The following is a description of a gene set: Human Gene Set: GOBP_HINDBRAIN_TANGENTIAL_CELL_MIGRATION The migration of a cell in the hindbrain in which cells move orthogonal to the direction of radial migration. studied in species Homo sapiens, and this is the list of marker genes: EPHB2, TTBK2, PHOX2B, EPHB1, PLXNA2